The following is a description of a gene set: Mouse Gene Set: GOBP_BONE_CELL_DEVELOPMENT studied in species Mus musculus The process whose specific outcome is the progression of a bone cell over time, from initial commitment of the cell to a specific fate, to the fully functional differentiated cell., and this is the list of marker genes: Pafah1b1, Notch2, Tyrobp, Tjp2, Anxa2, Cldn18, Atp6ap1, Fam20c, Tnfsf11, Ltf, Gpr68, Lrrk1, Ninj1, Fbn1, Siglec15, Fbxw7, Foxp1, Slc9b2, Src